Given this list of marker genes PPTC7, DNAJA2, TTI1, PAX7, GOLGA4, SYT6, AP1B1, PPARGC1A, ZSWIM3, NOVA1, SCNM1, ASXL1, MRPS28 (NCBI Gene Id 64947), ACOT8, ATAT1, RPL27, ESRRA, ZIC4 (NCBI Gene Id 84107), ZBTB40, APOM, SMYD5, PRRX2 (NCBI Gene Id 51450), CCDC71 (NCBI Gene Id 64925), PAK4, TP53BP1, EMG1, USP37, AGPS (alkylglycerone phosphate synthase), SNRPF (NCBI Gene Id 6636), EEF1B2, NR2F6, LYSMD1, GRPEL1, HSD17B8, CNTFR, CNOT9, RPRD1B, TBC1D22A, SRSF6, CSRNP3, RTP3, C1orf116, ADGRA2, NR2C1, FAM170A, NDUFS1, CUTA, here is a description of the gene set: studied in species Homo sapiens Genes having at least one occurrence of the motif NNWGRGGTCAAAGGTCANNNN in the regions spanning 4 kb centered on their transcription starting sites. This matches the PPARG transcription factor binding site V$PPARG_01 (v7.4 TRANSFAC). Human Gene Set: PPARG_01